The following is a description of a gene set: Human Gene Set: GOCC_PREFOLDIN_COMPLEX A multisubunit chaperone that is capable of delivering unfolded proteins to cytosolic chaperonin, which it acts as a cofactor for. In humans, the complex is a heterohexamer of two PFD-alpha and four PFD-beta type subunits. In Saccharomyces cerevisiae, it also acts in the nucleus to regulate the rate of elongation by RNA polymerase II via a direct effect on histone dynamics. studied in species Homo sapiens, and this is the list of marker genes: PFDN5, VBP1, PFDN2, PFDN6, PFDN4, PFDN1, PDRG1